Given this list of marker genes Lyz2 (NCBI Gene Id 17107), Defa43, Svs3a, Defb14, Prss1l, Defa29, Atox1, Pglyrp1, Eppin, Defa40, Defb47, Svs3b, Bpifb2, AY761185, Defa35, Pglyrp3, Defa32, Defb19, Defa27, Defb36, Defa42, Defa23, Defa22, Ltf, Bpi, Reg3g, Cd4, Defa26, S100a8, Itln1, Try4, Defb28, Camp, Defa3, Art1, Defa39, Defa25, Leap2, Defa37 (defensin, alpha, 37), Defa5, Bpifa1, Reg3b, Tlr2, Ear2, Defa21, Defa38, Bpifa2, Defb42, Clu, Defb25, Pdzd11, Prss1, Defa24, Reg3a, Defb21, Bpifb1 (BPI fold containing family B, member 1), Chga, Prss3l, Atp7a, Bpifb6, Pglyrp2, Defb43, Ccr6, Defa31, Pglyrp4, Defa20, Defa36, S100a9, Defa41, Prss2, Reg3d, Lcn2, Defb48, Defa2, Defa28, Defa30, Rnase6, Try10, Slc11a1, Defa34, Elane, Defb4, Defb30 (NCBI Gene Id 78130), Defb1, Try5, Defb18, Prss3, Tlr1, Prtn3, Defa17, Bpifb4, Pla2g2a, Ctsg, here is a description of the gene set: Antimicrobial peptides Mouse Gene Set: REACTOME_ANTIMICROBIAL_PEPTIDES studied in species Mus musculus